Given this list of marker genes Nlrp4c, Irf3, Dtx4, Sting1, Ddx41, here is a description of the gene set: electronically inferred by orthology from the curated human pathway Reactome Pathway: STING mediated induction of host immune responses studied in species Mus musculus part of: Cytosolic sensors of pathogen-associated DNA  This event has been computationally inferred from an event that has been demonstrated in another species.<p>The inference is based on the homology mapping from PANTHER. Briefly, reactions for which all involved PhysicalEntities (in input, output and catalyst) have a mapped orthologue/paralogue (for complexes at least 75% of components must have a mapping) are inferred to the other species.